Given this list of marker genes SDF4, DUSP4, HOPX, DENND1B, CDH1, IGKC, GPR65, UFL1, JUN, TCTN3, DUSP6, IL17RB, ENPP2, CD3G, FAM3C, TMEM45A, MEIS2, PNISR, RWDD1, MDFIC, PKIA, GZMB, ADGRL2, TSPYL1, GPR171, SERINC1, HTR3A, SERP1, PTPN3, MEF2C (NCBI Gene Id 4208), DNAJC15, ATP8A2, PMCH, PRUNE2, PECAM1, TRAV8-3, CD96, CTSA, DNAJB6, PTGS2, VAPA, LANCL1, YPEL5, REV3L, ADGRE1, ANXA1, ITGB1, MAOA, TTN, COL4A6, UBE2J1, CCNC, FYN, IGFBP7 (insulin like growth factor binding protein 7), FRY, CDK19, KHDRBS3, ATP5MG, PTPN2, STAP1, RPIA, AKAP9, GNLY, PDE4DIP, RIOX2, GZMA, CPVL, CEP192, CD86, here is a description of the gene set: Adult T-cell leukemia/lymphoma (ATLL) is a malignancy slowly emerging from human T-cell leukemia virus type 1 (HTLV-I)-infected mature CD4(+) T-cells. To characterize the molecular modifications induced by HTLV-I infection, we compared HTLV-I-infected WE17/10 cells with control cells, using micro-arrays. Many calcium-related genes were progressively downmodulated over a period of 2 years. Infected cells acquired a profound decrease of intracellular calcium levels in response to ionomycin, timely correlated with decreased CD7 expression. Focusing on apoptosis-related genes and their relationship with CD7, we observed an underexpression of most antiapoptotic genes. Western blotting revealed increasing Akt and Bad phosphorylation, timely correlated with CD7 loss. This was shown to be phosphatidylinositol 3-kinase (PI3K)-dependent. Activation of PI3K/Akt induced resistance to the apoptotic effect of interleukin-2 deprivation. We thus propose the following model: HTLV-I infection induces a progressive decrease in CD3 genes expression, which eventually abrogates CD3 expression; loss of CD3 is known to perturb calcium transport. This perturbation correlates with loss of CD7 expression and induction of Akt and Bad phosphorylation via activation of PI3K. The activation of the Akt/Bad pathway generates a progressive resistance to apoptosis, at a time HTLV-I genes expression is silenced, thus avoiding immune surveillance. This could be a major event in the process of the malignant transformation into ATLL. from publication Akl H, Badran BM, Zein NE, Bex F, Sotiriou C, Willard-Gallo KE, Burny A, Martiat P (PMID 17287851) Human Gene Set: AKL_HTLV1_INFECTION_DN species: Homo sapiens Genes down-regulated in WE17/10 cells (CD4+ T lymphocytes) infected by HTLV1 (and thus displaying low CD7) compared to the uninfected (i.e., CD7+) cells.